The following is a description of a gene set: part of: Diseases associated with surfactant metabolism studied in species Homo sapiens Reactome Pathway: Defective ABCA3 causes SMDP3_5688399 ATP-binding cassette sub-family A member 3 (ABCA3) plays an important role in the formation of pulmonary surfactant, probably by transporting phospholipids such as phosphatidylcholine (PC) and phosphatidylglycerol (PG) from the ER membrane to lamellar bodies (LBs). PC and PG are the major phospholipid constituents of pulmonary surfactant. LBs are the surfactant storage organelles of type II epithelial cells from where phospholipids can be secreted together with surfactant proteins (SFTPs) into the alveolar airspace. Defects in ABCA3 can cause pulmonary surfactant metabolism dysfunction type 3 (SMDP3; MIM:610921), resulting in respiratory distress in newborns and interstitial lung disease (ILD) in children., and this is the list of marker genes: ABCA3